The following is a description of a gene set: Human Gene Set: GSE5099_UNSTIM_VS_MCSF_TREATED_MONOCYTE_DAY3_UP from publication Martinez FO, Gordon S, Locati M, Mantovani A (PMID 17082649) Monocytes mature tom acrophages in the presence of the lineage determining cytokine M-CSF. They can be further polarized into M1 or M2 macrophages with distinct functional properties. We used microarrays to detail the global programme of gene expression underlying macrophage maturation and polarization and identified distinct classes of up-regulated genes during this process. Genes up-regulated in monocytes: untreated versus CSF1. species: Homo sapiens, and this is the list of marker genes: UQCRQ, ZNF566, NDUFV2, MCTP2, CCDC174, TTC13, YPEL5, ZBTB5, MDP1, MALAT1, ZDHHC14, CD200R1, GPC2 (NCBI Gene Id 2818), KCNMB2 (NCBI Gene Id 10242), KMO, RPGRIP1, CCDC162P, UQCR11, EFCAB2, DOP1A, CCNG1, PSMG4, PLAAT3, PPIL6, LIMS4, FRG1, ABHD6, KATNBL1, SIRT1, DPPA2, CBLB, YIPF5, CHM, CWC22, MAST4, ESM1, PRR23A, WDR3, HAPLN2, NPM3, ADK, LSM1, OGFOD1, KGD4, FAM3C, VPREB1, TLR7, SAP18, ZNF282, MAPK1IP1L (NCBI Gene Id 93487), UBQLN3, APBB2, FRRS1, RPL39L, HDAC1, TCF12, MICOS13, OR10A4, IRX3, DLL1, ZUP1, PUS3, DDX5, TEP1, NGDN, PWP1, PHOSPHO2, TRIQK, THEM4, PSRC1, KLRD1, MKKS, SS18L2, DDRGK1, ZSCAN5B, ARID1B, MPP1, RPL32, SNW1, SETD5, POLR2J, TRMT13, EFCAB14, SRP14, ATOX1, FLNB, MID1, PRRG3, STK3, IKZF2 (NCBI Gene Id 51173), RDH14, SLC25A31, GMPR2, RHOA, ECHDC1, LETM2, MTDH, RPS10, TMEM132D, RLN1, KLKB1, COX7A2, ZNF330, TMEM123 (transmembrane protein 123), VPS13C, USP8, MMUT, HMGCS1, SEC61G, TRMT10B, ARAF, CNIH4, NSMCE2, ZNF655, CHRAC1, SLC66A3, LARP7, TOMM7, CFAP57, POC5, MPP3, RNF170, DHX33, DUS1L, IPO8 (NCBI Gene Id 10526), FBXW2, OSTM1, BTBD10, EXOSC1, BEX1, PLXNA2, IL6R, VEGFD, RABGAP1L, CADM1, TSGA10, SEC61B, RAB5C, RNASE6 (ribonuclease A family member 6), CCNYL1, MYBL1, PGAM2, MRPL14, TPR, JAGN1, SLAMF9, ELP4, ROBO3, ZNF600, MBOAT7, LRRC39, ANAPC1, MATR3, ALG5, TEX30, TATDN2, RPS18, IFI27L2, KIF20B, FAM149B1, NCALD, CEP43, CD200, NIPSNAP1, ALOX5AP, CHUK, ARMC3, P2RY14, ITCH, FCRLA, C4orf33, LMO2, ITSN2, DRAP1, PJA2, HHATL, RGS10, TSPAN13, SRD5A1, HBP1, TRIM36, EIF1, NVL, FNDC3B, EPM2AIP1, METTL6, SH3BGR, CFAP418, OST4, WTAP, UGCG, DEGS1, GDI2, TOM1L1, CEP295, MATN2, CXCR3, CLN3, CLCN1